Given this list of marker genes TBX15, FOXI3, MED12, TWIST2, FGF3, here is a description of the gene set: Human Gene Set: HP_MICROTIA_FIRST_DEGREE Microtia, first degree studied in species Homo sapiens Presence of all the normal ear components and the median longitudinal length more than two standard deviations below the mean.